Given this list of marker genes HBD, RECQL, C1QBP, RPL31, BARD1, ETHE1, TRIB1, PSMB3, MS4A4A, G0S2, CDC42, S100P, MMP9, STAT1, SNCA, LILRA5, GLIPR1, ITM2A, CD160, H2BC21, TOP1, ARPC1A, H2AC18, EMC3, GLUL, ZBTB16, here is a description of the gene set: species: Homo sapiens Genes showing similar expression profiles in all subtypes of cutaneous T cell lymphoma (CTCL). Human Gene Set: HAHTOLA_CTCL_CUTANEOUS from publication Hahtola S, Tuomela S, Elo L, Häkkinen T, Karenko L, Nedoszytko B, Heikkilä H, Saarialho-Kere U, Roszkiewicz J, Aittokallio T, Lahesmaa R, Ranki A (PMID 16914566) PURPOSE: Increased production of Th2 cytokines characterizes Sezary syndrome, the leukemic form of cutaneous T-cell lymphomas (CTCL). To identify the molecular background and to study whether shared by the most common CTCL subtype, mycosis fungoides, we analyzed the gene expression profiles in both subtypes. EXPERIMENTAL DESIGN: Freshly isolated cells from 30 samples, representing skin, blood, and enriched CD4(+) cell populations of mycosis fungoides and Sezary syndrome, were analyzed with Affymetrix (Santa Clara, CA) oligonucleotide microarrays, quantitative PCR, or immunohistochemistry. The gene expression profiles were combined with findings of comparative genomic hybridization of the same samples to identify chromosomal changes affecting the aberrant gene expression. RESULTS: We identified a set of Th1-specific genes to be down-regulated in Sezary syndrome as well as in a proportion of mycosis fungoides samples. In both Sezary syndrome and mycosis fungoides blood samples, the S100P and LIR9 gene expression was up-regulated. In lesional skin, IL7R and CD52 were up-regulated. Integration of comparative genomic hybridization and transcriptomic data identified chromosome arms 1q, 3p, 3q, 4q, 12q, 16p, and 16q as likely targets for new CTCL-associated gene aberrations. CONCLUSIONS: Our findings revealed several new genes involved in CTCL pathogenesis and potential therapeutic targets. Down-regulation of a set of genes involved in Th1 polarization, including the major Th1-polarizing factor, TBX21, was for the first time associated with CTCL. In addition, a plausible explanation for the proliferative response of CTCL cells to locally produced interleukin-7 was revealed.